Given this list of marker genes Tmem199, Atp1b3, Atp6v0c, Atp2a2, Pln (phospholamban), Atp6v0a2, Atp1b4 (NCBI Gene Id 67821), Atp1b2, Tcirg1, Atp6v0d2 (NCBI Gene Id 77165), Atp6v1g2, Atp6v1b1, Atp6v1g1, Ccdc115, Atp6v1c1, Atp4a, Atp6v1a, Atp6v1g3, Rnasek, Atp1b1, Abcg8, Atp6v1b2, Fxyd4, Atp6v0e2, Atp6v0b, Slc9a1, Atp1a4, Atp6v0d1, Fxyd1, Atp6ap1l, Atp6ap1, Atp6v1f, Atp6v1h, Atp6ap2, Fxyd2, Atp6v0a4, Atp6v0a1 (NCBI Gene Id 11975), Atp1a3 (NCBI Gene Id 232975), Atp6v1c2, Atp1a1, Abcg5, Atp4b, Atp6v1d, Atp1a2, Atp6v0e, Spaar, Atp6v1e1, here is a description of the gene set: studied in species Mus musculus A transmembrane protein complex that functions in ATPase dependent active transport across a membrane. Mouse Gene Set: GOCC_ATPASE_DEPENDENT_TRANSMEMBRANE_TRANSPORT_COMPLEX